Given this list of marker genes CTTN, CALCR, ZNFX1, NINJ1, BMP5, NIBAN1, SYF2, BLOC1S4, SSTR1, RCE1, IQGAP1, SEC13, SMAD9, PACRG, DYRK1A, RAB38, DSPP, PACC1, LAPTM4B, ACKR3, TOR1A, WFS1, CLCN2, GOSR1, TTR, EIF2S2, SELENOW, PITPNB, ARGLU1, CRK, CD47, CPA1, DIPK1B, DDR2, BCKDHB, SPTSSB, CLEC5A, PLAAT1, ZBP1, VCAN, ALDOB, PLAGL2 (PLAG1 like zinc finger 2), TRIP12, RANBP17, TUBA8, MTF1, KLRK1, TNFSF9, TTYH1, PGF, NECTIN2, CCNL1, SLC28A2, ACTN3, RHPN2, PLEKHF2, GPR137B, SPON1, PIM1, PTPRO, CPLX4, IRS1, TIMP1, PKP4, CHGA, UBL7, FSCN1, EPSTI1, PI4K2A, GBP4, TYK2, CCL13, C19orf25, GAP43, GSPT1, PSMA4, ATP13A1, EGFR (NCBI Gene Id 1956), GCG, DUSP16, CDKN1A, PRICKLE1 (prickle planar cell polarity protein 1), GFRA4, PFDN2, STARD3, RIPK2, CSF2, SLC29A3, PC, MELTF, CNN3, DNAJC1, EMP1, DNAJB11, ACTN1, DDX4, FZD5, NRG4, CTSK, RBMS1, SYNE2, UBE2R2, YRDC, SLC2A5, TMEM243, BFAR, ARID3B, CXCR5, TEK, BLOC1S6, GPR50, KIF9, PCNX1, DUSP26 (dual specificity phosphatase 26), ABI1, PML, DNAJB1, SAP30L, PIP5KL1, PALLD, WASHC4, CACNG3, HMGA1, STXBP1, APPBP2, PLA2G2F, MS4A6A, HID1, SPTLC2, CLK3, SFT2D2, BCDIN3D, NUDT9, PIK3AP1, MCMBP, DTX2, CAPZA2, HDAC1 (histone deacetylase 1), PDE6D, RAB32, CYFIP2, MRPL14, COPS5, RPTN, SLC6A4, GDE1, SRSF7, MRPL39, HINFP (histone H4 transcription factor), NEMF, PHLDB1, DUSP11, NAE1, CYS1, TMEM192, OCIAD1, ATP6V1E1, TBK1, TAF7, IGF1R, CACYBP, TAB2, ABHD2, MAPK11, ANGPT1 (NCBI Gene Id 284), MITD1, ECE2, SPA17 (sperm autoantigenic protein 17), CES4A, MPZL2, DDA1, MRPL22, GBP2, EIF2S1, GUCD1, CD83, CENPM, CCL5, ADRA1A, GFPT2 (glutamine-fructose-6-phosphate transaminase 2), RNF114, COL4A4, UBL4B, IL10RB, PPP2R2D, ARNT2, GCA, RRP36, NSUN4, POU3F4, ARF4, HCN2, HTRA2, TPH1, CBLN1, ENKD1, NDRG2, UBAC2, CIITA, TYW5, here is a description of the gene set: species: Homo sapiens Genes down-regulated in comparison of control dendritic cells (DC) at 12 h versus those stimulated with poly(I:C) (TLR3 agonist) at 12 h. Human Gene Set: GSE17721_CTRL_VS_POLYIC_12H_BMDC_DN mouse primary BMDCs were stimulated with tlr ligands and gene expression changes were profiled on Affymetrix arrays from publication Amit I, Garber M, Chevrier N, Leite AP, Donner Y, Eisenhaure T, Guttman M, Grenier JK, Li W, Zuk O, Schubert LA, Birditt B, Shay T, Goren A, Zhang X, Smith Z, Deering R, McDonald RC, Cabili M, Bernstein BE, Rinn JL, Meissner A, Root DE, Hacohen N, Regev A (PMID 19729616)